The following is a description of a gene set: SUMOylation of immune response proteins species: Mus musculus Mouse Gene Set: REACTOME_SUMOYLATION_OF_IMMUNE_RESPONSE_PROTEINS, and this is the list of marker genes: Ikbke, Rela, Topors, Pias3, Nfkbia, Sumo1, Pias4, Ikbkg, Sumo3, Ube2i, Nfkb2